The following is a description of a gene set: species: Mus musculus Mouse Gene Set: chr15F2, and this is the list of marker genes: Krt1, Krt83, Gm35853, Krt84, Krt86 (keratin 86), Krt71, Krt5, Krt72, Spryd3, Zfp740 (NCBI Gene Id 68744), Krt6a, Soat2, Csad, Eif4b, Krt78, Gm5478 (NCBI Gene Id 432987), Krt88, Krt8, Krt90, Gm5477, Gm5414, Krt80, Gm17851, Krt6b, Krt81, Gm5476, Krt18, Gm36026, Tns2, Krt77, Igfbp6, Krt74, Krt75, Gm49428, Krt2, Krt4, Krt82, Krt87, Gm671, Krt73, Krt85, Krt76, Mir1941, Krt7, Krt79